Given this list of marker genes Ighg3, Igkv3-7, Igkv3-9, Jchain, Ighg2c, Igkv3-1, Igha, Igkv18-36, Pigr, Igkv3-3 (NCBI Gene Id 676222), Igkv3-5, Igkv3-2, Igkv3-12, Ighg2b, Ighe, Igkv3-4, Igkv3-10, Ighg1, Ighm, here is a description of the gene set: Mouse Gene Set: GOCC_IMMUNOGLOBULIN_COMPLEX_CIRCULATING studied in species Mus musculus An immunoglobulin complex that is secreted into extracellular space and found in mucosal areas or other tissues or circulating in the blood or lymph. In its canonical form, a circulating immunoglobulin complex is composed of two identical heavy chains and two identical light chains, held together by disulfide bonds. Some forms of are polymers of the basic structure and contain additional components such as J-chain and the secretory component.